Given this list of marker genes Mvp, Hbb-bt, Adam8, Tlr8, Ist1, Reg3d, Xrcc6, Slpi, Irf7, Rnaset2a (ribonuclease T2A), Ly86, Cul1, Olfm4, Tlr9, Gpr84, Arpc4, Cd36, Defa3, Prkacb, Ager, Psmd7, Ubb, Defa30, Tubb4b, Cd14, F12, C3ar1, Ube2n, Cfi, Mre11a, Nfkb2, Lta4h, H2-M9, Defb19, Capn1, Mcemp1, A2m, H2-M3, Klrc1, Sh3glb2, Colec10, Naprt, Leap2, Lpo, Adgre5, Psmc2, Lck, Erp44, Nhlrc3, Nlrx1, Yes1, Atp6v0d1, Defb21, Vav1, Ptpn6, Pla2g2a, Arl8a, Bpifb4, Cd19, Try10, C8g, Rab37, Lilra5, Sting1, Pak3, Clec4d, Ear6, Atp6v1e2, Tirap, Defb25, Tlr6 (NCBI Gene Id 21899), Mefv, Atp6v1g2 (ATPase, H+ transporting, lysosomal V1 subunit G2), Mapk12, Tnfaip3, Ilf2, Mapk13, Aldoa, Tab2, Defa24, Reg3a, Mapk8, Ppp2r1b, Cd209a, Arpc5, Eppin, Aim2, Camp, Clec4a3, Siglece, Acaa1b, C9, Tnfaip6 (tumor necrosis factor alpha induced protein 6), Defa26, Neu1, Lamtor1, Armc8, Tcirg1, Vtn, Lbp, P2rx7, Vat1, C4b, Cstb, Tnfrsf1b, Ddost, Psen1, Cpn1, Bpifa1, Tom1, Rab10, Nfkb1, Wasf3, Defa38, Hebp2, Psmc1, Prg2, 2310033P09Rik, Impdh2, Plau, Adgrg3, Irag2, Stk10, Gdi2, Txn1, Cd68, Defb42, Orm2, Cpped1, Atp6v1f, Rab3a, Cd3g, Pycard, Bri3, Rac2, Map2k3, Defa17, C1ra, Rigi, Cep290, Sdcbp, H2-Q7, Mapk7 (mitogen-activated protein kinase 7), 1600012H06Rik, Psmc6, Folr2, Hc, Psmb7, Man2b1, Cdk13 (NCBI Gene Id 69562), Fpr1, Ear2 (NCBI Gene Id 13587), Alad, Anpep, Npc2, Creg1, Slc2a5, Reg3g, Gsdmd, S100b, Qpct, Defb47 (NCBI Gene Id 654465), Ptges2, Rps6ka5, Fabp5, Cotl1, Defa20, Defa32, Icam2, Psmd12, Crisp2, Pik3c3, Rnase2b, Svs3b, Kcmf1, Atp8a1, Ormdl3, Panx1, Irf5, Psmc5, Fth1, Optn, Grn, Casp8, Birc3, Ctsg, Map3k8, Atp6v1g3, Hexb, Gsn, Prg3, Kcnab2, Ifi205, Serpinb3c, C5ar2, Defb48, Unc93b1, Ctsd, Map2k6, Oscar, Casp9, Psmb5, Ikbkb, Snap29, Vcp, Anxa2, Vamp8, Psmb6, Card9, Defa37, Dsg1a, Colec11, Cxcl1, Rps27a, Cxcr1, Atp6ap2, Actr10, Hvcn1, Atp6v0a1, Serpinb3b, Eef1a1, C1qa, Psma1, Pdap1, Actr3, Kng2, Serpinb3a, Eef2, Psma2, H2-M10.6, Casp2, Serping1, C5ar1, Peli2, Ep300, Klrd1, C1qb, Casp3, Irak1, Clec12a, Ctsh, Klrc3, Elane, Cracr2a, Cr1l, Shc1, Cap1 (NCBI Gene Id 12331), Calm1, Gstp1, Psma4, Defa31, Mmp8, Ctsc, Psg22, Mapk11, Jup, Defb36, Defa41, Nlrc5, Tyrobp, Cda, Clec4a2, Fgr, Ms4a3, F2, Dusp6, Psg29, Apob, Ap1m1, Fos, Ube2d1, Ckap4, Bpifa2, Rab6a, C8a, Kpnb1, Cct8, Aldh3b1, Defa34, Cd46, Vps35l, Cnn2, Epx, Hras, Ticam2, Crispld2, Cd81, Ly96, H2-M10.1, Defa39, C3, Pdpk1, Nlrp4c, Lgmn, Dtx4, Igll1, Grap2, Pdzd11, Cdc42, Nfasc, Pa2g4, Arsa, Masp2, Cystm1 (NCBI Gene Id 66060), Nfam1, Defb14, Atp6v0a4 (NCBI Gene Id 140494), Itgal, Hp, Cdc34, Rab18, Pfkl, Psma7, Rab7, Copb1, Defa35, Mavs, Tlr4, Fcer1a, Clec4n, Lamp2, Fcnb, Prkaca, Hrg, Svip, Malt1, C6, Masp1, Dynll1, Arg1, Plaur, Sugt1, Ncf2, Slc44a2, Cfd, Ddx41, Clec4a4, Tlr2, Pnp, Pld2, Cd55, Siglecf, Arpc2, Mapk14, Tec, Trim32, Nme2, Slc27a2, Cyld, Cd300e, Prss2, Rab5c, C1s2, Psmd1, Psma5, Nfkbib, Ampd3 (NCBI Gene Id 11717), Psmd6, Itk, Rab44, Nf2, Bcl2l1, Pkm (pyruvate kinase, muscle), Ncf1, Tab1, Atp6v1c2, Glipr1, Ptk2, H2-Q10, Mapk9, Prss3, Map2k7, Rap2c (RAP2C, member of RAS oncogene family), Psmc3, Cd300lb, Crk, Dok3, Trim56, Atp6v0e2, Klkb1 (kallikrein B, plasma 1), Defb1, Reg3b, Plcg2, Apeh, Ceacam2, Hmgb1, Atp11b, Csnk2b, Ifi211, Defb28, Defb3, Defa28, Dock2, Psmd13, Ifi204, Lat, Pglyrp3, Mmp25, Galns, Psmc4, Ptprc, Psma3, Itgb2, Lcp2, Tspan14 (tetraspanin 14), Wasf1, Unc13d, Defa36, Tlr1, Prcp, Defa43 (NCBI Gene Id 665956), Lamtor2, Pigr, Grb2, Fcna, Prdx4, Fyn, Tifa, Pglyrp4, Pstpip1, Defa25, Psma6, Nos2, Klrk1, Actr2, Defa42, B2m, Cmtm6, Tasl, Rnase6, Pglyrp1, Rbsn, Cpn2, Mospd2, Mif, Faf2, Atp6v0c, Vnn1, Frmpd3, Arhgap9, C2, Nfkbia, Pgm2, Nlrp3, Vapa, Rnase2a, Pik3r2, Orm1, Dusp7, Psmb4, Ecsit, Defa23, Dnase1l1, Defb43 (NCBI Gene Id 654458), Ppp2r5d, Tarm1, Fgl2, Cxcr2, Syk, Cyfip2, Tlr7, Klrc2, Gzmm, Slco4c1, Igf2r, Cant1, Arhgap45, Bpi, Pld3, Rela, Ppp3r1, Art1, Chit1, Ppia, Bpifb6, Ear10, Bpifb1, Ceacam1, Sftpd, Tab3, Hk3, Ctss, Defa21 (NCBI Gene Id 66298), Jun, Rab9b, Casp1, Cd177, Clec4b2, Clec4b1, Mbl2, Map3k14 (mitogen-activated protein kinase kinase kinase 14), Irf3, Cfp, Siglecg, Chga, Myd88, H2-M10.2, Defb18, H2-M2, Ahsg, Itgax, Atg7, Dynlt1a, Cyba, Ctnnb1, Pnp2 (purine-nucleoside phosphorylase 2), Dynlt1b (NCBI Gene Id 21648), Enpp4, Ccr6, Map2k4, Dnm2, Trem1, Cst3, Pik3cb, Atp6v1a, Ghdc, Mapk3, Tmem30a, Ube2v1, Tmem63a, Ear1, Trem2 (triggering receptor expressed on myeloid cells 2), Nckipsd, Atp6v1d, Cct2, Fadd, Psap, Lrrc14, Fgg, Atp6v0e, Prtn3, Relb, Casp4, Pla2g6, Vrk3, Hmox2, Hsp90b1, Traf3, C1qc, Nkiras1, Slc11a1, Ms4a2, here is a description of the gene set: This event has been computationally inferred from an event that has been demonstrated in another species.<p>The inference is based on the homology mapping from PANTHER. Briefly, reactions for which all involved PhysicalEntities (in input, output and catalyst) have a mapped orthologue/paralogue (for complexes at least 75% of components must have a mapping) are inferred to the other species. Reactome Pathway: Innate Immune System part of: Immune System species: Mus musculus electronically inferred by orthology from the curated human pathway